Given this list of marker genes Upf2, Mdfic, Ogn, Fam177a2, Msr1, Keap1, Bnc2, Bicd2, Irx2, Slc15a1 (NCBI Gene Id 56643), Tcf24, Slc7a11, Cxadr, Lnx1, Meioc, Fam168a, Atp2b1, Tnrc6b (trinucleotide repeat containing 6b), Glra2, Fam169a, Cyp2d22, Shox2, Scn8a, Cpt1a, Ttbk2, Apobec1, Serinc1, Ppm1k, Hdx, Rufy2 (RUN and FYVE domain-containing 2), Or10d5j, Atad2b, Tenm4, Zdhhc3, Lbh, Trim52 (NCBI Gene Id 212085), Adhfe1, Efhc2, Mtf2, Sfxn1, Cycs, Luc7l2, Glis3, Rbfox1 (RNA binding protein, fox-1 homolog (C. elegans) 1), Kdm7a, Ncam1, Egln1, Smim13 (NCBI Gene Id 72908), Ppfia2, Dnm1l, Megf11, Satb1, Cul3, Ppp6r2, Palld, Zic2, Unc79, Mecp2, Chl1, Nr2c2, Hivep2 (human immunodeficiency virus type I enhancer binding protein 2), Trps1, Gbp7, Lpp, Unc5b, Vbp1, Klf9, Sema3e, Nlgn1, Tead1 (TEA domain family member 1), Gm6040, Vrk1, Zfp704, Bbx, Tet2, Gria2, Adcy5, Map1b, Emx2, Dusp10, Cdc42bpa, Coro2a, Dapk1, Tmod2, Ednrb, St6galnac1, Zc3h12c, Slc5a8, Pou2f1, Chchd6, Dmrt1, Aqp4, Akr1c21, Frmd7, Slc6a6, Fgf18 (fibroblast growth factor 18), Ddx3x (DEAD box helicase 3, X-linked), Slc30a4, Sp9, Ciita, Arl4a, Itprid2, Fam177a, Klhl1, Cbll1, Tjp1, Hivep3, Lrp3, Lilra5 (NCBI Gene Id 232801), Pmch, P2rx7, Col19a1, Plp1, Bdnf, Ids, Ptprt (protein tyrosine phosphatase receptor type T), Esyt3, Marchf4, Zeb1 (NCBI Gene Id 73165), Phex, Sorcs1, Cdc14b, Sorbs2, Prlr, Mtpn, Slc25a21, Kxd1, Pfn2, Abhd18 (NCBI Gene Id 99688), Armc8, Dmd, Bahcc1, Bmp2k, AI182371, Atp6v1b1, Cracd, Igsf3, Magi3 (NCBI Gene Id 99548), Ncbp2, Polr2k, Tardbp, Dmtf1, Tfap2b (NCBI Gene Id 98405), Cavin2, Ugt2b36, Selenop, Rab27b, Erbb4, Txlng, Tmem174, Rbms3, Taok3, Stxbp5, Gmps, Yeats2, Dkc1, Kif26a, Naaladl2, Ntrk3, Fgfbp3, Zfp40, Nrp2, Gxylt1, Foxo1, Cep170, Endod1, Lrrc2, Atg4c, Smg1, Ceacam1, Neb, Kcnd2, Apaf1, Dync1i2, Abca1, Srsf1 (serine and arginine-rich splicing factor 1), Xirp2, Tut4, Ccdc90b, Kcnq5, Insr, Tox, Pik3ca, Ap5m1, Cdk6, Mgat4c (NCBI Gene Id 67569), Robo1, Dnmt3a, Tmem30a (transmembrane protein 30A), Steap2, Nsd3, Ywhae, Kpnb1, Igf1 (NCBI Gene Id 320499), Dcaf5 (NCBI Gene Id 320808), Prkaa2, Dcdc2a, Lrrtm2, Uox, Hycc2, Il36b, Plagl2, Ubash3b, Tdpoz1, Brinp1, Zfp612, Mafg (NCBI Gene Id 319360), Pcdh11x, Ube3a (NCBI Gene Id 76097), Hs3st3b1, Erbin, Irx3, Vezt, Fam120a (family with sequence similarity 120, member A), Fam20b, Ppm1e, Pax9, Map4k5, Colec11, Thsd4 (thrombospondin, type I, domain containing 4), Car10, Rora, Hnf4g, Rorb, Msx3, Gabpb2, Commd8, Zyg11b, Grm5, Zbtb20 (zinc finger and BTB domain containing 20), Serbp1, Lgalsl, Ago4, Rnf8 (ring finger protein 8), Desi1, Ccnd2, Abcd2, Ddx6, Slc16a4, Arih1, Nol4, Nova2, Gadl1, BC005624, Chdh (choline dehydrogenase), Ppp2r5e, Cdk14, Traf3, Fgf10 (fibroblast growth factor 10), Tmeff2, Tmed10 (transmembrane p24 trafficking protein 10), Cdcp1, Fat3, Cnn2, Acvr2a, B230219D22Rik, Adgrl3, Col8a1, Mllt3 (NCBI Gene Id 77576), Slc8a3, Ints7, Slitrk1, Arl6ip6, Smad6, Fmo2, Ndst3, Rnf150, Mfhas1, Zbed4, Fbxw7, Nav1, Hmcn1, Elovl6, Crls1, Osbpl11, Hdac4, Pdzrn4 (NCBI Gene Id 73717), Npy2r, Arl15, Fam98a, Kremen2, Pdzd8, Pdlim5, Camk4, Zfhx3, Cep15, A630001G21Rik, Slc16a14, Lrrc32, Tril, Zfp281, Rprd2, Zfp759, Plcl1, Rgs17, Ppp2cb, Acp1, Hpgds, Celf4, Dixdc1, Erlec1, Socs2, Arhgap17, Smad2, Dmrta1, Gsdma, Gsk3b, Tent5c, Brd3, Slc7a9, Pik3r3, Fundc1, Faxc, Agap1, Rp2, Jazf1, Fstl4, Tceal7, Patj, Ubxn2b, Lrrc4, Zmym2, Osbpl6, Abca5, Thrap3, Ppp3ca, Plk4, Rnf222, D1Pas1, Jag2, Phf21a, Bicd1 (NCBI Gene Id 319962), Abcd3, Rasgrp3 (NCBI Gene Id 240168), Shprh (NCBI Gene Id 70331), Rslcan18, Pml, Klhl13, Pclo, Deptor, Klhl15, Ptprb, Notch2, Pmp2, Csnk1g3, Ccng1, Cacna1b, Ssbp2, Ncam2, Col11a1, Clp1, Pakap, Ssh2, Tbx4, Gna11, Ythdc2, Xrn2, Scml4, Rfx3, 5730455P16Rik, Tnp1, Fbxl2, Garem1, P4ha3, Slc17a6, Bloc1s2, Oacyl, Jarid2, Purb, Mysm1, Tmem167, Celf2, Arrdc3 (arrestin domain containing 3), Krtap19-5, Far2 (NCBI Gene Id 330450), Cldn12, 1110059G10Rik, Lman1, Kmt5a, Ahdc1, Neurod2, Pogz (pogo transposable element with ZNF domain), Lcorl, Hdac9, Atxn1, Hsf2bp, Hook3, Lrch2, Gmfb, Enpp1, Cdh4 (NCBI Gene Id 99327), Asb7, Tmf1, Cacul1, Nucks1, Foxp1, Tenm2, Rreb1 (NCBI Gene Id 68750), Thrb, Ntrk2, Sobp, Aldh8a1, Fbxo42 (NCBI Gene Id 77742), Zfp711, Clock, Ythdf1, Fstl5, Ep300, Dsg2, Cttnbp2nl, Usp31, Bbs7, Rcn2 (NCBI Gene Id 27014), Ssrp1, Prkg1, Cadm2, Rnase1, Tob2, Prdm5, Pbx1, Pla2g2d (NCBI Gene Id 18782), Aebp2, Cntnap2 (NCBI Gene Id 66797), Hoxb6, Zfp462, Prps1l3, Slc5a3, Crebrf, Xkr6 (NCBI Gene Id 72545), Pkp2, Tiparp, Atrx, Nmnat2, Ebf1, Tmem72, Septin2, Nfatc1, Ube2q1, Liph, Nab1, Zbtb11, Tbx3, Zfp267, Sim1, Slc24a5, Ccdc77, Zfp503, Stap1, Atxn7l1 (ataxin 7-like 1), Nrxn2, Gnaq, Ncs1, Bcan, Clcn2, Sncaip, Seh1l, Xcr1, Nt5c2 (5'-nucleotidase, cytosolic II), Abcc9, Zfp654, Ctps2, Cntd1, Unc5d, Camta1, Svs3a, Haus6, Serpinb10, Nrxn1, Cadm1, Acbd3, Ppara, Fhip1a, Qser1, Hcrtr2, Hoxb1, Lrrc10, Gpr101, Cbln2, Lrrtm3, Kcnd3, Nufip2, Fam124b, Ptprj, Kcns2, Tmem260, Bmi1, Bcl9, Mdga2, Plekhg1, Ppp2r2b, Il1rl1, Raph1, Mgst2, Clec2i, Bnip3l, Mal, Adamts5, Bicra, Xpr1, Rfx7, Abhd17b, Fam168b, Pank1, Stxbp5l, Igf2, Cxxc4, Brcc3, Uvssa, Pou2f2, Clmn, Fbxl21, Fut9, Scyl3, Tlr5, Scn2a, Tfap2d, Csrnp2, Ncor1, Six1, Fbxo48, Tab3, Taok1, Ajap1, Cnot11, Mmp21, Qki, Casd1, Tmtc1, Mef2a, Yipf5, Ank1, G3bp1, Ypel5, Bcl11a, Dzip1, Nalf1, Hdgfl3, Nck1, Fbxo30, Xpo7, L2hgdh, Slc8a1, Enpp6, As3mt, M6pr (NCBI Gene Id 17113), Stox2, Dgkg, Ntng1, Uqcc1, Cfl1, Zmynd11, Tmtc4, Lrrc4c, Zfp536, Ppargc1a, Cfap141, Diaph2, Ctnnal1, Frk, Sspn, Ccr9, Vapa, Cyp2c23, Cpne4, Srgap1, Zeb2, Rpp25, Sox4 (NCBI Gene Id 20677), Acsm4, Ppp1r2, Zbtb26, Zbtb44, Fzd3, Map3k20, 1700025G04Rik, Ralgapb, Vwc2l, Grm3, Phip, Tlr11, Cyld, Grip1, Galntl6, Plekha8, Epha4 (Eph receptor A4), Adam19, Gm14322, Spred2, Hs6st2, Strbp, Pi4k2b, Nup160, Angpt2, Col4a3, Map3k2, Adcyap1, Arl5a (ADP-ribosylation factor-like 5A), Scai, Mospd2, Sacm1l, Foxb1, Zfp788, Kitl, Ugt8a, D16Ertd472e, Cdc42ep3, Cnot4, Plcxd3, Gcnt1, Six4, Mapk8, Wsb1, Bcl11b, Sgms1, Tmcc3, Ugcg, Slco3a1, Dach1, Hnrnpr, Sntg1, Hecw2, Brinp2, Gabrb2, Cacng2, Tbl1x, Tdpoz9, Samd4b, Xpo1, Lhfpl3, Sox12, Sox6, Rimklb, Tgfb2, Ppfibp2, St6galnac3, Zfp735, Zfp385b, Tent5a, Plxna2, Itm2b, Col23a1, E130308A19Rik, Epb42, Npepps, Neo1, Gad2, Rb1cc1, Cstf2, Ms4a6c, Vip, Sfmbt1, Ar, Sytl5, Eif2s2, Lamp2, Nfib, here is a description of the gene set: Genes predicted to be targets of miRBase v22 microRNA mmu_miR_7234_5p in miRDB v6.0 with MirTarget v4 prediction scores > 80 (high confidence targets). Mouse Gene Set: MIR_7234_5P from publication Chen Y, Wang X (PMID 31504780) species: Mus musculus